Given this list of marker genes Pkd2, Wnt11, Smad2, Hey1, Lzts2, Smad6, Hnf1b, Smad9, Bcl2, Tcf21, Six2, Eya1, Cd44, Gsta3, Ctnnb1, Fgfr2, Kif26b, Pax8, Mir217, Six1, Cited2, Gata3, Smad4, Bmp4, Smo, Fgf10, Dchs1, Fgfr1, Pax2, Sox8, Ctnnbip1, Hoxb7 (NCBI Gene Id 15415), Lgr4, Arg2, Ilk, Agt, Spry1, Pkd1, Bdnf, Gli3, Grem1, Ptch1, Mir216b, Agtr1b, Cat, Hs2st1, Hoxa11, Ret, Tmem59l, Cer1, Robo2, Smad1, Sdc1, Dlg1, Fat4, Npnt (NCBI Gene Id 99581), Foxd1, Foxc1, Lhx1, Agtr2, Bmp7, Tacstd2, Maged1, Sim1, Cited1, Gzf1, Fgf8, Sall1, Smad3, Gdnf, Gpc3, Ren1, Bmp2, Tshz3, Hoxd11, Wnt2b, Osr2, Nog, Pgf, Wnt6, Crlf1, Pbx1, Slit2 (NCBI Gene Id 338531), Gdf11 (NCBI Gene Id 14561), Smad7, Calb1 (NCBI Gene Id 12307), Hs3st3a1, Fmn1, Rarb, Foxc2, Bmper, Hs3st3b1 (NCBI Gene Id 54710), Fgf2, Adamts16, Dspp, Mir216a, Wnt4, Lama5, Fgf1 (NCBI Gene Id 14164), Wt1, Myc, Foxj1 (forkhead box J1), Wnt1, Vegfa, Six4, Epcam, Agtr1a, Rara, Greb1l, Osr1, Timeless, Sfrp1, Wnt9b, Sox9, Sdc4, Hes1, Vcan, Smad5, Pspn, Shh, Tgfb1, here is a description of the gene set: species: Mus musculus Mouse Gene Set: GOBP_MESONEPHROS_DEVELOPMENT The process whose specific outcome is the progression of the mesonephros over time, from its formation to the mature structure. In mammals, the mesonephros is the second of the three embryonic kidneys to be established and exists only transiently. In lower vertebrates such as fish and amphibia, the mesonephros will form the mature kidney.